The following is a description of a gene set: Human Gene Set: FERRARI_RESPONSE_TO_FENRETINIDE_DN from publication Ferrari N, Pfeffer U, Dell'Eva R, Ambrosini C, Noonan DM, Albini A (PMID 15958647) Genes down-regulated in HUVEC cells (umbilical vein endothelium) by fenretinide. PURPOSE: Tumor growth appears to be an angiogenesis-dependent process. N-(4-hydroxyphenyl)retinamide (fenretinide; 4HPR) has been found to inhibit and/or prevent tumor growth under diverse conditions. Although 4HPR is antiangiogenic, the molecular mechanisms of this effect remain largely unknown. EXPERIMENTAL DESIGN: Endothelial cells were treated with 4HPR in vitro to study the effects on migration, invasion, and organization, as well as gene expression by microarray and quantitative PCR studies. In vivo angiogenesis was evaluated in the Matrigel model. RESULTS: 4HPR treatment substantially modified the biological activities of endothelial cells, repressing their capacity to migrate, invade, and organize into capillary-like structures. The inhibition of invasion induced by 4HPR was also associated with decreased activities of the metalloproteases matrix metalloproteinase-2 and CD13/APN. Using oligonucleotide microarrays, we observed that bone morphogenetic protein-2 and macrophage inhibitory cytokine-1, two multifunctional cytokines of the transforming growth factor-beta family that regulate the growth, differentiation, apoptosis, and matrix accumulation of a variety of cells, are up-regulated in vitro by 4HPR. Both these molecules specifically inhibited endothelial cell growth, migration, and invasion in vitro and suppressed angiogenesis in the Matrigel plug assay in vivo. Blocking antibodies to bone morphogenetic protein-2 were able to reverse the suppressive effects of 4HPR in vitro and in vivo. CONCLUSIONS: These data support the conclusion that 4HPR inhibits tumor growth by repression of new vessel growth and identify novel points of regulation of angiogenesis in transforming growth factor-beta family proteins. species: Homo sapiens, and this is the list of marker genes: LDLR, PPP1R3C, HSPA2, TFF3, CD34